The following is a description of a gene set: Enables the transfer of a negatively charged ion from one side of a membrane to the other. studied in species Mus musculus Mouse Gene Set: GOMF_MONOATOMIC_ANION_TRANSMEMBRANE_TRANSPORTER_ACTIVITY, and this is the list of marker genes: Clcn6, Clic3, Slc12a2, Slc26a7, Slc26a8, Slc1a1, Clcnkb, Slc5a5, Ttyh1, Slc12a5, Clcnka, Clca1, Clca4b, Tmc4, Ano10, Slc6a1, Best1, Vdac1, Gabrp, Slc26a9, Nmur2, Gabra5, Gpr89, Clic6, Slc26a6, Vamp8, Apol9b, Ano9, Slc6a3, Apol10b, Panx1 (NCBI Gene Id 55991), Clic5, Clca2, Slc1a6, Apol11b, Slc12a8 (solute carrier family 12 (potassium/chloride transporters), member 8), Gabrb2, Mcoln1, Ano4, Slc26a11, Gabra4, Gabra1, Slc17a8, Slc12a4, Lrrc8c, Gabrr2, Chrm5, Stx1a, Glra2, Slc26a3, Slc6a12, Slc6a18, Slc12a1, Ttyh3, Gabrg3, Glra3, Slc26a5, Slc25a14, Glrb, Slc6a8, Clcc1, Gabrb1, Ucp2, Gabre, Slc17a3, Slc4a5, Ano5, Cldn17, Apol9a, Slc4a2, Slc6a6, Gabra2, Best2, Gabrb3, P2rx5, Slc26a10, Slc26a2, Ano8, Ano1, Aqp6, Ano6, Clca4a, Ttyh2, Clcn3, Slc4a8 (NCBI Gene Id 59033), Clcn1, Gabrq, Clic1, Slc17a6, Clcn7, Slc18a1, Ano2, Slc22a3, Nherf1, Gabrr1, Slc1a7, Glra4, Mcoln3 (NCBI Gene Id 22316), Slc4a4, Ano3, Ano7, Stx7, Shoc2, Gabrr3, Pacc1, Gabrg2, Slc6a4, Slc26a1, Lrrc8a, Clcn4, Slc4a3, Vdac3 (NCBI Gene Id 22335), Best3, Slc4a7, Slc18a2, Chrna7, Oca2, Clic4, Bsnd, Clca3b, Clcn2, Slc6a13, Slc12a9, Cftr, Slc1a2, Lrrc8b, Apol8, Vdac2, Trpv1, Lrrc8e, Slc22a1, Vti1b, Clca3a2, Slc4a1, Clca3a1, Slc12a3, Gabra6, Apol11a, Clcn5, Gabra3, Apol10a, Glra1, Slc26a4, Slc6a2, Gabrg1, Slc19a1, Slc1a4, Slc12a7, Slc17a7, Mfsd8, Slc5a6, Slc6a11, Slc4a10, Slc39a14 (NCBI Gene Id 213053), Slc13a1, Gabrd, Stx8, Slc4a9, Cldn4, Slc12a6, Slc25a27, Lrrc8d